The following is a description of a gene set: Human Gene Set: HP_ABNORMAL_5TH_FINGER_PHALANX_MORPHOLOGY Abnormal 5th finger phalanx morphology species: Homo sapiens Abnormality of the phalanges of the 5th (little) finger., and this is the list of marker genes: MKS1, BBS10, ERF (NCBI Gene Id 2077, ETS2 repressor factor), SRCAP (NCBI Gene Id 10847), WNT5A, ZNF141, BHLHA9, DVL1, GJA1, SMARCB1, NPR2, PUM1, GNB2, IFT74, IGF2, CFAP418, RBBP8, TTC8, IFT27, ATP6V1B2, BBS9, RAI1, HOXD13, BBS1, BMP2, NPHP1, MKKS, CEP19, ERI1, MYCN, SCLT1, ROR2 (receptor tyrosine kinase like orphan receptor 2), IFT140, HNRNPR, COL2A1, SDCCAG8, IFT172, ARID1B, LZTFL1, BBS4, NIN, WDPCP, BBIP1, TRIM32, BMPR1B, BBS5, BBS12, BBS7, KIF15, RUNX2, PUF60, TFAP2B, SCAPER (S-phase cyclin A associated protein in the ER), NOG, TBX5, BBS2, CEP290, ARL6, GDF5